Given this list of marker genes Lcp2, Trem2, B2m, Pik3cb, Klrc2, Grap2, Pik3ca, Hras, Lat, Lck, Plcg1, Sos1, Rac1, Grb2, Tyrobp, Klrk1, Pik3r2, Klrd1, Syk, Fyn, Kras, Klrc3, Vav2, Btk (Bruton agammaglobulinemia tyrosine kinase), Vav3, Pik3r1 (phosphoinositide-3-kinase regulatory subunit 1), Plcg2, Klrc1, Shc1, here is a description of the gene set: DAP12 signaling studied in species Mus musculus Mouse Gene Set: REACTOME_DAP12_SIGNALING